Given this list of marker genes SOX9, BMP4, CTNNB1, WNT2B, TNF, WNT2, here is a description of the gene set: studied in species Homo sapiens Human Gene Set: GOBP_REGULATION_OF_BRANCHING_INVOLVED_IN_LUNG_MORPHOGENESIS Any process that modulates the rate, frequency, or extent of the process in which a highly ordered sequence of patterning events generates the branched structures of the lung, consisting of reiterated combinations of bud outgrowth, elongation, and dichotomous subdivision of terminal units.